Given this list of marker genes Pmp22, Ret, Sptbn4, Ccdc39, Tbx6, Nrcam (neuronal cell adhesion molecule), Adgrb3, Ngf, Opa1, Kcnma1, Anks1, Kcnq2, Kcnb1, Ank3, Lgi4, Epha8, Ednra, Gata2, Gsk3b, Bcl11a, Irx5, Lrrk2, Abl2, Cntn2, Farp2, C1ql1, C1qa, C3, Cntnap2 (NCBI Gene Id 66797), Actl6b, B4galt5, Rac1, Mir132, Mtor, Cspg4, Fbxo41, Lhx6, Kcnip2, Myoc, B4galt6, Nox1, Rnd1, Gldn, Grip2, Mecp2, Nrxn1, Rac3, App, Dlg2, Dleu2, Cdkn1c, Vsx1, Nr4a2, Spg21, Kdm1a, Rb1 (NCBI Gene Id 19645), Pdgfb, Smim45, Gnaq, Mir133b, Akap5, Mir212, Bcl2, Ednrb, Nfasc, Scarf1, Map3k13, Ntn4, Srrm4, Fev, Kcnq3, Sclt1, here is a description of the gene set: A developmental process, independent of morphogenetic (shape) change, that is required for a neuron to attain its fully functional state. studied in species Mus musculus Mouse Gene Set: GOBP_NEURON_MATURATION